Given this list of marker genes Sptlc3, Sptlc2, Sptlc1, Sptssa, Sptssb, Gm6993, here is a description of the gene set: Mouse Gene Set: GOMF_C_PALMITOYLTRANSFERASE_ACTIVITY Catalysis of the transfer of a palmitoyl group to a carbon atom on the acceptor molecule. species: Mus musculus